Given this list of marker genes TRIM58, ATP1B2, STATH, POU4F1, SLC12A4, SLC30A3, RREB1, ZNF157, EFNA3, IGHMBP2, PRSS16, LY6G6C, VAMP1 (vesicle associated membrane protein 1), CARD10, MC2R, KAT7, GRK2, TNP1, WNT10B, PVT1, KRT2 (NCBI Gene Id 3849), ST3GAL2, PSG1, PFKFB2, PCBP3, IGSF9B, ITGA2B, NCKIPSD, SULT4A1, KRT33A, ADCYAP1, MLANA, BUD23, CYP11A1, ZKSCAN3, KRT86, here is a description of the gene set: species: Homo sapiens Neighborhood of WBSCR22 Williams Beuren syndrome chromosome region 22 in the CAR expression compendium Human Gene Set: CAR_WBSCR22 Neighborhood of WBSCR22